Given this list of marker genes Actr3, Plk1, Mei1, Fmn2, Spire1, Shcbp1l, Actr2, Spire2, Washc1 (WASH complex subunit 1), Orc4, Washc5, here is a description of the gene set: A cell cycle process that results in the division of the cytoplasm of a cell after meiosis, resulting in the separation of the original cell into two daughter cells. Mouse Gene Set: GOBP_MEIOTIC_CYTOKINESIS studied in species Mus musculus